Given this list of marker genes SMOC1, BMPR1B, CEP120, HYLS1, DYNC2H1, SLC31A1 (solute carrier family 31 member 1), BHLHA9, LAMA5, FLNB, LMBR1, SHOX, PITX1, GLI3, LIFR, GDF5, CHD7 (NCBI Gene Id 780907), ATP7A, NEK1, GPC6, DONSON, EIF4A3, ZSWIM6, IHH, INTU, ALG12, SLC35A2, LONP1, MEG3, SHH, RTL1, TCTN3, DLK1, here is a description of the gene set: Aplasia/Hypoplasia of the tibia studied in species Homo sapiens Absence or underdevelopment of the tibia. Human Gene Set: HP_APLASIA_HYPOPLASIA_OF_THE_TIBIA